Given this list of marker genes Inpp5k, Grk2, Prkcb, Ace, Upk3b, Il1b, Stxbp3 (syntaxin binding protein 3), Ostn, Pid1, Appl2, Rhoq, Enpp1, Pea15a, Sh2b2, Lep (leptin), Sirt6, Gsk3a, Fabp5, Prkca, Grb10, Myc, Ahi1, Tnf (NCBI Gene Id 21926), Cers1, Esr1, here is a description of the gene set: Any process that decreases the frequency, rate or extent of glucose transport across a membrane. Glucose transport is the directed movement of the hexose monosaccharide glucose into, out of or within a cell, or between cells, by means of some agent such as a transporter or pore. species: Mus musculus Mouse Gene Set: GOBP_NEGATIVE_REGULATION_OF_D_GLUCOSE_TRANSMEMBRANE_TRANSPORT